The following is a description of a gene set: Human Gene Set: chr15q26 studied in species Homo sapiens, and this is the list of marker genes: SPATA8, IDH2, GOLGA2P8, MESP1, LINC02852, LINC02207, ZNF774, OR4F14P, ENSG00000289128, RCCD1-AS1, RPL7P5, LINC00928, MIR3175, MIR3174, UNC45A, GABARAPL3, WDR93, ENSG00000259403, ENSG00000275443, WASH3P, RN7SL484P, LINC01581, HSPE1P3, HNRNPA1P62, MEF2A, ENSG00000259478, MIR5094, SPATA41, MCTP2, MIR3529, RHCG, LINC02348, ASB7, CERS3-AS1 (CERS3 antisense RNA 1), IDH2-DT, ST8SIA2, RNA5SP401 (RNA, 5S ribosomal pseudogene 401), SNRPA1, NR2F2, ABHD2, RN7SKP181, RPL36AP43, POLG, ZNF710-AS1, TM2D3, DDX11L9, OR4G2P, DUXAP6, FES, OR4G6P, RN7SL346P, RPS12P26, TTLL13, ENSG00000299260, THRAP3P2, RNU6-132P, SYNM, PGAM1P12, ENSG00000259219, NGRN, LYSMD4, RNU7-111P, LINC03080 (long intergenic non-protein coding RNA 3080), LINC02157, RNA5SP402, CERS3, FAM138E, VPS33B, RNU7-195P, GCAWKR, PEX11A, TARS3, LINC00923, HDDC3, MIR1302-10, MIR6859-3, OR4F13P, RPL31P6, SNRPCP18, OR4F28P, ISG20, HAPLN3, SPATA8-AS1, C15orf32, RNU2-3P, SNRPA1-DT, LINC02253, YBX2P2, ENSG00000258489, ENSG00000259704, RNU6-1111P, MIR5009, ANPEP, CRAT37, OR4F6, HMGB1P8, DET1 (DET1 partner of COP1 E3 ubiquitin ligase), ENSG00000259182, ENSG00000259755, RNU6-807P, NDUFA3P4, MIR9-3, RN7SL677P, MFGE8, UBE2Q2P13, SLCO3A1, ZNF710, KRT18P47, MIR9-3HG, DDX11L16, NR2F2-AS1, MIR4714, RN7SL363P, FTLP20, KIF7, FANCI, LETR1, CHD2, IQGAP1, HMGN1P38, AP3S2, TICRR, CRTC3, LINC02251, ASB9P1, HSP90B2P, PLIN1, SEPHS1P2 (selenophosphate synthetase 1 pseudogene 2), RN7SL209P, POLGARF, RNU6-322P, LINC00924, RNU6-181P, TTC23, ENSG00000286917, MIR7-2, SYNM-AS1, CRTC3-AS1, SEMA4B, ENSG00000282793, RCCD1, DNM1P46 (dynamin 1 pseudogene 46), RN7SKP254, LINC01582, ARRDC4, LINC01579, RNU6-1186P, SELENOS, H3P40, MRPL15P1, FAM149B1P1, ACAN, VPS33B-DT, LINC00930, CHASERR, ALDH1A3-AS1, BLM, LINC01585, TUBAP12, SYNM-AS2, MIR1179, PRC1-AS1, ARPIN, FURIN, SV2B, RLBP1, LINC02244, H2AZ2P1, LINC02351, LUNAR1, PGPEP1L, IGF1R, MIR6766, PERPP2, LRRC28, LINS1, FAM169BP, OR4F4, ENO1P2, OR4F15, TTC23-AS1, CIB1, POLG-DT, NPM1P5, MIR1469, LINC01586, AEN, PRC1, PCSK6-AS1, PRKXP1, RGMA, IRAIN, DNM1P47, CARMAL, ARPIN-AP3S2, ADAMTS17, CHSY1, FAM174B, RN7SL736P, GOLGA8VP, ENSG00000287000, ALDH1A3 (NCBI Gene Id 90476), PCSK6, MAN2A2, GDPGP1, SNORD18, MESP2, WBP1LP5 (WBP1L pseudogene 5), LRRK1